Given this list of marker genes GAB3, TSC22D3, TCF7, HSD17B8, HID1, H1-2, JAKMIP1, BBS9, ADAMTS6, TTC39C, H2AC6, TRIM13, PPP3CC, FOXO3, B3GNT5, CCND2, ACTR6, CD72, RNF167, CRTAM, S1PR5 (NCBI Gene Id 53637), SIDT1, EMB, ABTB3, RAP2A, CD96 (CD96 molecule), IQSEC1, BAG5, NARS2, L3MBTL3, HPCAL1, OTUD1, ELOVL7, TRAT1, SLC25A51, MBD5, CD55, JUNB, PJA1, PRSS12, CRIM1, SEC16A, ST6GALNAC3, MOCOS, BORCS7, CYRIA, ASCC1, ANGPTL7, F2RL2, PIK3C3, CCDC125, BCOR, HS3ST3B1, RAB6B, KDM5B, ADRB2, NRP1, MYLIP, FOXJ2 (forkhead box J2), PHF21A (PHD finger protein 21A), KAT6B, SH2B1, KDM7A, CD226 (NCBI Gene Id 10666), NFE2L1, CBX7, BBS2, RPL4, PPP1R13B, DNAJB2, GPR155, CD2, TRAF1, CHMP1B, ZBTB25, EML5, IMMP1L, NHLRC3, DGUOK, YPEL5, CARD6 (caspase recruitment domain family member 6), SGMS1, KLF3, TNRC6C, RPTOR, ADCK2, CXCR6, PITPNC1, SAMD3, SMAD3, XPC, NT5E, MAML2, MFSD6, SMPDL3A, KIZ, ATP6V1G3, PRRG4, LRRC61, PSTK, ZBTB20, USE1, ACSS2, GGPS1, CEP164, CCDC191, TMEM65, ZRANB1, MPPE1, GIMAP3P, VKORC1, FBXO32, FOXP1, ACSS1, ITPR2, LATS2, SNX29, TCP11L2, SMIM31, PARP16, MYO3B, NOP53, MICU3, ZNHIT6, SMIM12, IL27RA, KLRC2, DMRTA1, SPATA6, DNTTIP2, CD247, TESPA1, PLEKHM3, PEX6, SMAD5, PPM1H, TDRP, PNPLA7, NR1D2, KBTBD11, DZIP1, KLF7, TBRG1, AS3MT, SMYD3, GIMAP5, SLCO3A1, KCNJ8, TASL, HERPUD2, HYI, RPL19, GABARAPL2, QPCT, AXIN2 (NCBI Gene Id 8313), KLRC1, IL7R, FPGT, PUS3, FYCO1, RASGRP1, INSYN2B, SPRY2, here is a description of the gene set: studied in species Homo sapiens The gene expression profile of peripheral Foxp3+ natural regulatory T cells isolated from Foxp3/EGFP bicistronic mice was compared to that of in vitro-induced regulatory T cells and to CD4+ conventional (Foxp3-) T cells. The role of the regulatory T cell transcription factor Foxp3 in shaping the transcriptosomes of natural and induced regulatory T cells was analyzed using mice expressing a mutant FOXP3-EGFP fusion protein (Foxp3deltaEGFP). We used gene expression microarrays to examine the transcriptional programs of natural and induced regulatory T cells and the function of Foxp3 in organizing the transcriptosomes of the respective cell type from publication Haribhai D, Lin W, Edwards B, Ziegelbauer J, Salzman NH, Carlson MR, Li SH, Simpson PM, Chatila TA, Williams CB (PMID 19265124) Human Gene Set: GSE14415_INDUCED_TREG_VS_TCONV_DN Genes down-regulated in induced T reg versus T conv.